The following is a description of a gene set: Human Gene Set: GOBP_REGULATION_OF_MRNA_METABOLIC_PROCESS Any process that modulates the frequency, rate or extent of mRNA metabolic process. studied in species Homo sapiens, and this is the list of marker genes: YBX1, MIR564, CSDC2, CELF6, RBM15B, SLC11A1, NICOL1, PUM1, MIR544A, MIR27B, RBPMS, LARP4B, MAPK14, MIR181A2, MAGOHB, MIR485, SRPK1, MIR302C, CELF5, CDK9, MIR520C, ANGEL2, RBM11, PRPF19, MIR151A, SRSF1, QKI, SON, DAZ3, RBPMS2, MIR424, MIR125B1, CELF3, RBM47, MIR223, RBMX, NOVA2, CNOT9, NT5C3B, BAG4, KHSRP, PCBP4, NOCT, AGO4, NCBP1, MIR106B, CNOT3, RBFOX2, MIR135B, SNW1, MIR199B, PLEKHN1, NUP98, MIR519A1 (microRNA 519a-1), LARP1, CNOT1, MAPKAPK2, SMU1, BTG2, ARB2A, UPF3A, FMR1, MIR18A, RC3H1, MIR195, SRSF10, TAF15, RBM3, MIR181D, CNOT2, ZFP36L1, MIR320A, RBM46, WTAP, FBLL1, MIR34B, ELAVL4, RBFOX3, HNRNPAB, RBM33, IGF2BP2, PRMT5, HNRNPC, CNOT11, ELAVL1, RBM23, MIR486-1, DIS3 (NCBI Gene Id 22894), DHX36, IGF2BP1, IKBKE, MIR200C, HNRNPA1, MIR1-1, ROCK1, PNPT1, MIR373, MIR625, MIRLET7C, RBM39, SECISBP2, MIR665 (microRNA 665), CALCR, MIR210, NPM1, RBM4, MIR517A, SRPK3, IWS1, MLH1, EIF4ENIF1, TIA1, FASTKD3, MIR93 (microRNA 93), MIR181C (NCBI Gene Id 406957), SRSF6, NORAD, FXR2, CLNS1A, TNRC6B, PAN3, MIR24-1, CPEB3, PUF60, TNRC6C, CNOT7, DHX34, PKP3, YTHDF3, HMX2, E2F1, DCPS, MIR181B1, KHDRBS1, FXR1, CNOT10, RBM5, FAM76B, DAZ1, RBM24, RBM8A, CPEB1, PNLDC1, DYRK1A, YTHDC1, ALKBH5 (alkB homolog 5, RNA demethylase), PRKCA, PRKCD, PDE12 (phosphodiesterase 12), AGO2, METTL14, YBX3, SRSF3, MIR483, PAIP1, ZC3H12D, AGO1, THUMPD2, CELF4, FASTKD5, MIR302A, PKP1, HNRNPA0, AXIN2, PTCD2, RBMXL1, FASTKD1, MIR23A, ZC3HAV1, SRPK2, TENT5C, TENT4B, RBMY1E, GTPBP1, TARDBP, MIR27A, TENT5A (terminal nucleotidyltransferase 5A), SAFB, DIS3L2, SRSF12, STH, TNRC6A, MIR214, ZFP36L2, MYOD1, DND1, MIR133A1, TIRAP, HNRNPU, RBMY1F, MIR192, CDC73, MIRLET7B, NCL, NBAS, TRA2B, ACIN1, DDX5, MIR30B, CIRBP, MIR491, MIR149, CELF1, MOV10, RBM42, SRRM1, FASTKD2, CSDE1, MIR26B, MIR106A, CNOT6, SFSWAP, DCP1B, TUT7, NCBP2, AHCYL1, METTL16, SAFB2, RBM20, MIR130B (microRNA 130b), SAMD4B, KHDRBS2, MIR562, RIDA, PIWIL2, MIR191, TRAF5, RNPS1, DCP1A, MIR517C, PARN, BARD1, MIR9-1, NOVA1, MIR543, TNKS1BP1, FASTK, MIR497, CNOT4, DCP2, U2AF2, MIR193A, TTC5, MIR206, MIR519D, CACNG7, MIR342, MIR103B1, THRAP3, MIR203A, TRAF2, MIR185, AGO3, RNASEL, PIAS4, BOLL, POLR2G, MIR96, CNOT8, MIR19B1, MIR19A, CARHSP1 (NCBI Gene Id 23589), MIR4286, SRSF8, AKT1, MIR340, RBMY1J, SCGB1A1, ZBTB7A, MIRLET7E, MIR329-1, MIR128-1, MIR337, MIR98, RBM10, MEX3D, GDNF, SLC39A5, SRSF9, DDX17, MYD88, MIR20B, REST, RBMY1A1, MIR140, NANOS3, MIR142, ZC3H12A, MIR501, RBMY1D, NRDE2, KHDRBS3, LARP7, MIR130A, PIWIL1, SERBP1, FUS, SENP1, A1CF, VIM, TOB1, MIRLET7A1, MIR204, ZC3H14, HNRNPK, UPF3B, MIR29B1, JMJD6, GIGYF2, MIR212, RBM25, FTO, SRSF7, PRDX6, RBMY1B, PATL2, PATL1, SAP18, SRSF2, RBM38, UPF1, TENT5B, MIR20A, TRAF3IP2, CNOT6L, SRRM4 (serine/arginine repetitive matrix 4), RBM15, MIR423, MIR885, PRR5L, HDAC7, ARID5A, CAPRIN1, SYNCRIP, PABPC4, RBM7, DAZ2, SLTM, SRSF4, MIR708, IREB2, CDK11B, MEIOC, TENT5D, MIR146A, PABPC1, NANOS2, EIF4A3, TENT4A, PTBP1, APEX1, TBRG4, MIR663A, IGF2BP3, DAZ4, SAMD4A, WDR77, ZAR1, MIR137, PAN2, CCNB1 (NCBI Gene Id 891), GTSF1, TRA2A, CELF2, MAGOH, ZFP36, CDK11A, ROCK2 (NCBI Gene Id 9475), C1QBP, TRIM71, HNRNPD, LARP1B, RC3H2, METTL3, CASC3, PABPN1L (NCBI Gene Id 390748), NANOS1, HNRNPL, TUT4, MIR608, NSRP1, MIR655, SF1, DAZAP1, EXOSC10, SNRNP70, VIP, MIR125A, MIR145, YTHDF1, DHX9, YTHDF2, MIR200B, ARGLU1, MIR365A, MIR190B, RBFOX1, KAT8, MIR100, CWC22, LSM1, DAZL, MIR495, APOBEC1, MIR211, MIR326, PUM2